The following is a description of a gene set: from publication Chen Y, Wang X (PMID 31504780) Genes predicted to be targets of miRBase v22 microRNA mmu_miR_7055_3p in miRDB v6.0 with MirTarget v4 prediction scores > 80 (high confidence targets). Mouse Gene Set: MIR_7055_3P species: Mus musculus, and this is the list of marker genes: Chl1, Med13, Septin10, Zfpm2, Wdr47, Cdh2, Ccdc121rt1, L3mbtl4, Sdad1, Sap30l, Zfp260, Atp1b1, Mark3, Dgki, Grm5, Fry, Jak1, Chd7, Pramel7, Pdp1, Dcaf10, Kit, Ppp1cb, Akip1, Sec23a, Shtn1, Gm5460, Rnf145, Fndc3a, Oxsr1, Lpin3, Galnt1, Ube2h, Lmbrd1, Mapkap1, Chm, Rgs6, Phactr3, Llcfc1, Ppp2r3d, Aida, Cpeb2, Brwd3, Itm2b (integral membrane protein 2B), Syt13, Bcl2l13, Prdm6, Atad5, Pkn2, Mfap3l, Zfp157, Dstn, Thrsp, Necab3, Bnip3, Stil, Apoa5, Cngb1, Dennd6a, Ccdc93, Mecp2, Ankrd13a, Eda2r, Zmym2, Rgl1, Pcgf6, Ubxn8, Zfp30, Nbeal1, Steep1, Sstr3, Ccdc88a, Shisa9, Elp4, Tssk2, Sbk1, Sox11, Tbc1d2b, Zcchc2, Zpbp2, Edar, Zfp385a